Given this list of marker genes EYA4, MDGA2, XPO4, PTPN2, TET3, BIVM, PRDM8, ARG1, MCMDC2, DCLRE1B, GDF11, LRCH3, LRCH2, SLC2A13, DSCC1, OTP, ARMC9, LAPTM4A, KALRN, SH3GLB1, MCM9, MMS22L, MEGF10, DSG3, TBX18, GPR137C, KLF4, TTC39C, SRSF3, PHTF2, DELE1, ARHGAP6, TAF4B, ATP11C, FH, COL19A1, ACADM, KYNU, HERPUD2, SAMD12, TYRP1, ADAM20, TXNRD2, CCDC47, PLCH1, EXOC1, SEH1L, ZDHHC17, MBNL3, PF4V1, VLDLR, CELF1, NHLRC2, GRIA2, REST, TRIM9, NDRG4, SCUBE3, CDKN2C, PCDH10, KCNB1, LIN54, DLC1, ZBTB18, PLXNC1, TIA1, TBL1XR1 (NCBI Gene Id 81612), IGF2BP3, STK4, ZEB1, SUZ12, SRP68, DUSP1, SPRED1, CNIH1 (NCBI Gene Id 10175), ZNF655, RIOK2, TMEM123, VAT1, DUT, GNG11, WDR41, CDH10, ARL4C, SLC25A30, CSN2, CREB5, YEATS4, HNRNPH3, INO80D, COX15, FCGBP, SLC7A9, C1QTNF7, FSD1L, TMCC1, AEBP2 (NCBI Gene Id 121536), ICOS, OTULIN, SLFN11, DCUN1D3, YPEL5, USP9X, LRRC4, GMCL1 (germ cell-less 1, spermatogenesis associated), SNX1, TRPC1, YIPF6, CPSF6, SGO1, PDS5B, OSBPL8, BLOC1S3, FCRL2, here is a description of the gene set: Human Gene Set: MIR4720_3P Genes predicted to be targets of miRBase v22 microRNA hsa-miR-4720-3p in miRDB v6.0 with MirTarget v4 prediction scores > 80 (high confidence targets). from publication Chen Y, Wang X (PMID 31504780) species: Homo sapiens